Given this list of marker genes SEMA3F, MAL, GLULP4, IL6ST, IFI27, GUCY1A1, EZR, BAHCC1, TGM2, BCL11A, MIR22HG, VASN (NCBI Gene Id 337957), MAP7, DAPK1, SKAP2, HOXA4, NFKBIB, MSI2, FGFR1, CHURC1, NBL1, ADGRE1, SFTPB, CD3D, SLC2A1, SLC6A8, PXDN, AGT, DMWD, CKMT1B, ISG20, COL1A1, SMG1, TBXAS1, GLUL, UGGT2, TUBB2A, EML4, NFKB1, SNX9, ADGRB2, S100P, WDR82, FOXO1, PLIN2, HOXB5, LDAH, TACSTD2, SELENBP1, TMEM158 (NCBI Gene Id 25907), PMEPA1, ENDOD1, TCF4, PLCG1, NR2F2, CNN3, CTNNAL1, HOXB2, NFIB, S1PR1, FLT3, UGCG, FHL2, CDC42EP4, SRPX, PALM2AKAP2, PIK3R4, TSPAN7, PBX3, PMP22, TSPAN32, SLC7A7, SMG1P2, PRG2, FARP1, LCN2, GYPC, DENND4B, AGRN, HOXA10, ANGPT1, here is a description of the gene set: Patients with acute myeloid leukemia (AML) and normal karyotype are classified in an intermediate-risk group, albeit this subset is heterogeneous for clinical outcome. A recent complementary DNA microarray study identified a gene-expression signature that--when used to cluster normal karyotype patients--separated them into 2 prognostically relevant subgroups. We sought the first independent validation of the prognostic value of this signature. Using oligonucleotide microarrays to measure gene expression in samples from uniformly treated adults with karyotypically normal AML, we performed cluster analysis based on the previously identified signature. We also developed a well-defined classification rule using the signature to predict outcome for individual patients. Cluster analysis confirmed the prognostic utility of the signature: patient clusters differed in overall (P =.001) and disease-free (P =.001) survival. The signature-based classifier identified groups with differences in overall (P =.02) and disease-free (P =.05) survival. A strong association of the outcome classifier with the prognostically adverse FLT3 internal tandem duplication (FLT3 ITD) potentially explained the prognostic significance of the signature. However, in the subgroup of patients without FLT3 ITD there was a moderate difference in survival for the classifier-derived groups. Our analysis confirms the applicability of the gene-expression profiling strategy for outcome prediction in cytogenetically normal AML. Human Gene Set: RADMACHER_AML_PROGNOSIS The 'Bullinger validation signature' used to validate prediction of prognostic outcome of acute myeloid leukemia (AML) patients with a normal karyotype. from publication Radmacher MD, Marcucci G, Ruppert AS, Mrózek K, Whitman SP, Vardiman JW, Paschka P, Vukosavljevic T, Baldus CD, Kolitz JE, Caligiuri MA, Larson RA, Bloomfield CD, Cancer and Leukemia Group B (PMID 16670265) studied in species Homo sapiens